Given this list of marker genes DLGAP5, SRSF3, WTAP, IGFBP7, H2BC21, LUC7L3 (LUC7 like 3 pre-mRNA splicing factor), CENPF, SRSF7, MAD2L1, PLK1, PPM1B, KIF20A (NCBI Gene Id 94421), HMMR, SCD5, FXYD2, GTSE1, SPP1, VPS41, CD248, here is a description of the gene set: from publication Xu J, Gao M, Fan S, Meng Q, Goldberg ID, Abounader R, Ressom H, Laterra JJ, Rosen EM (PMID 17099727) Human Gene Set: XU_HGF_SIGNALING_NOT_VIA_AKT1_48HR_DN The cytokine scatter factor (SF) (hepatocyte growth factor) transduces various biologic actions, including cell motility, invasion, angiogenesis and apoptosis inhibition. The latter is relevant to understanding the role of SF in promoting tumor cell survival in different contexts, for example, detachment from basement membrane, growth in metastatic sites and responses to chemo- and radiotherapy. Previously, we showed that SF protects cells against apoptosis owing to DNA damage, by a mechanism involving phosphoinositol-3-kinase/c-Akt signaling. Here, we used DNA microarray assays to identify c-Akt-regulated genes that might contribute to cell protection. DU-145 human prostate cancer cells were transfected+/-a dominant-negative mutant Akt, treated+/-SF and analysed for gene expression using Affymetrix arrays. These studies identified SF-regulated genes for which induction was c-Akt-dependent vs -independent. Selected microarray findings were confirmed by semiquantitative and quantitative reverse transcription-polymerase chain reaction. We tested the contribution of four SF-inducible/c-Akt-dependent genes (AMPD3, EPHB2, MX1 and WNT4) to protection against adriamycin (a DNA topoisomerase IIalpha inhibitor) using RNA interference. Knockdown of each gene except EPHB2 caused a small but significant reduction in the SF cell protection. The lack of effect of EPHB2 knockdown may be due to the fact that DU-145 cells contain a single-mutant EPHB2 allele. A combination of three small interfering RNAs blocked most of the protection by SF in both DU-145 and T47D cells. These findings identify novel c-Akt-regulated genes, some of which contribute to SF-mediated cytoprotection. species: Homo sapiens Genes down-regulated in DU-145 cells (prostate cancer) in the absence and presence of a dominant negative form of AKT1 upon exposure to HGF for 48 h.